The following is a description of a gene set: Genes down-regulated in Th17 cells 15 days post polarization: control versus stimulated with anti-CD3 and anti-CD28. species: Homo sapiens Serial comparison between Th1 and Th17 tumor-specific cells cultured in vitro and ex vivo after transferred into sublethaly irradiated B6.PL mice. Th17-derived cells acquire Th1-like properties in vivo but maintain a distinct molecular profile. from publication Muranski P, Borman ZA, Kerkar SP, Klebanoff CA, Ji Y, Sanchez-Perez L, Sukumar M, Reger RN, Yu Z, Kern SJ, Roychoudhuri R, Ferreyra GA, Shen W, Durum SK, Feigenbaum L, Palmer DC, Antony PA, Chan CC, Laurence A, Danner RL, Gattinoni L, Restifo NP (PMID 22177921) Human Gene Set: GSE26030_UNSTIM_VS_RESTIM_TH17_DAY15_POST_POLARIZATION_DN, and this is the list of marker genes: ADISSP, CXCR4, STX7, RPSA, CTSF, ZNF622, ITPRIPL2, RAB14, RYBP, WTAP, TBL2, CTRL, ABTB3, DDX17, SF3A2, PHAF1, ADGRL1, CRLF2, GRN, HGH1, INVS, KCNK6, CAPZB, TNFAIP2, DNAJA2, SMARCD2, ARFIP1, ACTN4, ANO6, TMEM109, WDR19, FAT4, CCM2, SH3BP2, CSNK1A1, PLA2G4D, SLFN5, SUDS3, CHIT1, TLE3, SYNJ2, RASGEF1A, TMCO4, RPS4X, CD99, FERMT3 (FERM domain containing kindlin 3), TUBA1A, MST1R, SLC17A3, CEP55, ABCA5, ATP6V0C, COA5, TAGLN2, KDM2B, HIPK2, FNBP1, KNOP1, HEXIM1, NINJ1, REL, RHBDF1, NCAPH2, QDPR, NMU, TKT, ADAMTS3, UTP14A, PPEF2, GREM2, ANXA9, ANAPC5, RPL23, SLA, MARCHF5, TMEM176A, PI16 (peptidase inhibitor 16), ZAP70, CHMP4B, CTDSP2, ACTR2, LGALS3, MYADM, ATXN7L3B, ERF, EEIG2, FXYD6, SYNJ1, NHERF1, LCORL, ADAR, UNC93B1, SHISA5, ICAM1, MKNK2, FLRT1, TRIM28, INTS5, RASSF4, RAB21, GRK6, DCTN1, SCARB2, GDI2, ZNF436, PSME4, ITGA10, TUBA1B, ASAH1, IPO7, FOS, DNAJA1, UBXN7, CDK2AP1, RBM12, ARL6IP5 (NCBI Gene Id 10550), RANBP10, IDS, PRPF19, MCCC1, RITA1, TUBA4A (tubulin alpha 4a), PIGB, KLHDC3, CLTA, GNAI2, PIP4K2A, PSORS1C2, CEP164, SLC7A8, EID1, PGD, HSPA8, CTNNB1, ARPC2, SULF2 (NCBI Gene Id 55959), PTGS1 (prostaglandin-endoperoxide synthase 1), CCNY, SNX24, CSTB, MMP2, CDIPT, NLRP3, MAP1LC3B, SLC43A2, NAT8L, ATP2A2, ARIH2, RIT2, DCAF1, MCL1, CDKN1B, RIPK1, AGBL5, SIK1, OAZ1, UBC, CMIP, CADM2, CAMTA2, PIK3R6, FAM120A, ZNF362, OGFR, DGKZ, DCUN1D4, MID2, PPT2, ZBTB42, PXN, KIFBP, CLASP2, NPC2, ABHD16B, HLA-E, RERE, ING3, ELOVL5, NSMF, RTN4, SERBP1, CDK16, ARHGEF4, ARL14, ACAP2 (ArfGAP with coiled-coil, ankyrin repeat and PH domains 2), SNX17, NONO, BMS1, COTL1, DNAJB9, ADGRL4, SLC7A2, DNAJB1, SAMD12, SELENOP, CSTF3, RAB8B, NUP62, PLAAT1, OS9